The following is a description of a gene set: Human Gene Set: GSE16450_IMMATURE_VS_MATURE_NEURON_CELL_LINE_DN Genes down-regulated in the neuron cell line: immature versus mature. Human neuronal differentiation alters responsiveness to innate immune stimuli and virus infections. We used microarrays to examine the transcriptional responses of the human BE(2)-C neuroblastoma cell line to retinoic acid-induced differentiation and type I IFN stimulation. from publication Peltier DC, Simms A, Farmer JR, Miller DJ (PMID 20483728) studied in species Homo sapiens, and this is the list of marker genes: PFKP, USP14, CCNB1, EIF2B3, RRP9, ORC6, ZWILCH, TNFRSF9, TNFSF14, PEMT, DPH2, FARSA, CENPN, COPRS, COL6A3, CDC20, INSM1, FNTB, METTL1, C1orf216, MAPK13 (NCBI Gene Id 5603), TRIP6, KBTBD8, KNSTRN, EIF4EBP1, NOP14, C9orf40, MFSD2A, CDK6, IL12RB2, GRAMD4 (GRAM domain containing 4), NCLN, CENPU, POLR2D (RNA polymerase II subunit D), ST20, VDR, FXN (NCBI Gene Id 2395), TIMM50, B3GNT5, LRP8, MAGOH2P, TRAP1, NUDC, SLC3A2, C17orf58, TNIP3, PHGDH, PUSL1, MMAB, DDX56 (DEAD-box helicase 56), IRF8, SHMT2, EGR3, NDFIP2, ARMCX1, RFC3, TOMM34, NEFH, NANP, TIMM8A, ZWINT, NOC4L, BLM, UTP20, EPOP, CDC45, TRIP13, OIP5, TNFRSF4, UBE2T, TNF, HELLS, KCNK6, THOP1, IL10 (interleukin 10), TTK, CDCA7, URB2, ZBED2, ACY1, MYBBP1A, HILPDA, FDX2, NPRL3, POLE2, LIF, SPAG1, SFXN4, SLC25A17, PRR3, CALCB, EXOSC4 (NCBI Gene Id 54512), GINS2, GINS3, UTP4, IL17A, PDCD11, SDC4, GALR2, PA2G4, TMEM97, BCL2L1, FOSL1, NPM3, TIMM13, MRPS34, TOMM40, UCK2, LTA, PINX1, NOP2, GPT2, DTL, NETO2, PPAN, KCNK5 (potassium two pore domain channel subfamily K member 5), GFOD1, EVI5, TIMM44, AMD1, STIP1, RBBP8, SLC1A5, RPE, POFUT1, SNRPC, PLAGL2, CYP27B1, SUV39H2, IL3, NTMT1, WRAP53, MRPL4, IL2RA, SLAMF1, TLCD1, KIF3B, NUDT4, HOMER1, SLC16A1, DDX49 (DEAD-box helicase 49), AURKA, RFC2, GOT1, VPS37C, PCBD1, CD200, YBX3, LAG3, DDIAS, CAMK2D, IL9, CCDC86, NEU1, CLUH, EZH2, IL22, AGK, NOL6, TTLL12, HSF5, ZNRD2, DHRS7B, CHAF1A, ABCF2, CHEK1 (NCBI Gene Id 1111), ALYREF, ESPL1, GTF2H2, MCM4, RRP1, IL17F, ACAD9, POLR1A, CAMTA2, RAB11FIP1, FANCE, MRRF, LIG3, HPDL, CD320, SLC38A5 (NCBI Gene Id 92745), UHRF1, ALG1, F5, C19orf48P, SERPINE2, HIVEP3, SNX8, FRMD4B, POLD2, DDX51, BPNT2, MED27, POLR3G, SLC25A19, IL2, PCLAF